The following is a description of a gene set: Genes having at least one occurence of the motif CCACACA in their 3' untranslated region. The motif represents putative target (that is, seed match) of human mature miRNA hsa-miR-147 (v7.1 miRBase). Human Gene Set: CCACACA_MIR147 studied in species Homo sapiens, and this is the list of marker genes: POGK, PLP1, ATP1A1, CAPN6, STC1, CAMTA1, C6orf120, AHCYL1, ANK1, ZNF451, MYLK2, MNT (MAX network transcriptional repressor), ROBO2, GOLPH3L, TIPARP, JMJD8, PNPLA6, RGS3, SLC25A51, SSR1, INHBB, GRID1, CYP20A1, HDLBP, CREB5, CREBRF, PPP2R1B, PPP4R3A, DNMT3A, MAPKAPK5-AS1, ZNF827, CREBBP, CTDSPL, ACLY, DLG4, SEMA3F, MECP2, RECK, ACOT11, KLF7, PURA, SLC44A1, NEUROG2, MAPRE3, DHDDS, TRIOBP, NFAT5, MAL2 (mal, T cell differentiation protein 2), SHOC2, RAD23B, PDPK1, UBTD1, SNRPA, ZEB2, BCOR, CYP2S1, DHX57, NR3C1, LIMD1, ADIPOR2, GCN1, PCMT1, GPRC5B